Given this list of marker genes XPC, H4C4, ERCC6, ERCC2, POLH, ERCC3, H4C2, GTF2H2, LIG1, CUL4A, RAD18, H4C5, GTF2H4, UVSSA, H3-3A, ERCC8, H2AC6, RFC3, PCNA, GTF2H1, LIG3, BRCA1 (BRCA1 DNA repair associated), GTF2H2C, H3-3B, RPA2, HMGN1, RFC5, CHD1L, H4C11, ERCC1, DDB1, H4C8, POLD4, DDB2, RPA1, POLE2, MNAT1, POLD1, H4C14, ERCC4, H4C12, CETN2, GTF2H5, RFC1, RAD23B, H4C6, H4C15, POLD2, RFC4, SLX4IP, POLE4, H4C9, XAB2, POLD3, POLE, H4C13, GPS1, H4C1, RAD23A, USP7, CUL4B, SLX4, CCNH, H4C3, XPA, GTF2H3, RFC2 (replication factor C subunit 2), RBX1, PARP1, H4C16, POLK (DNA polymerase kappa), XRCC1, CDK7, POLE3, RPA3, here is a description of the gene set: Nucleotide excision repair in xeroderma pigmentosum studied in species Homo sapiens Human Gene Set: WP_NUCLEOTIDE_EXCISION_REPAIR_IN_XERODERMA_PIGMENTOSUM